Given this list of marker genes CDC25C, PCBP4, CCNA2, SFN, E2F1, CCNE1, CNOT10, RGCC, CCNB1, CNOT3, BTG2, RBL1, E2F8, CNOT4, TNKS1BP1 (NCBI Gene Id 85456), CDKN1A, CNOT8, CARM1, ZNF385A, PCNA, PLK2, E2F4, PRMT1, BAX, CNOT7, E2F7, CNOT2, CNOT6, CNOT1, NPM1, CPAP, EP300, ARID3A, CDKN1B, RBL2, CNOT11, CCNE2, PLK3 (NCBI Gene Id 1263), TP53, CDK2, PLAGL1, CDK1, CCNA1, TFDP2, GADD45A, TFDP1, CNOT9, CNOT6L (NCBI Gene Id 91275), AURKA, here is a description of the gene set: species: Homo sapiens Under a variety of stress conditions, TP53 (p53), stabilized by stress-induced phosphorylation at least on S15 and S20 serine residues, can induce the transcription of genes involved in cell cycle arrest. Cell cycle arrest provides cells an opportunity to repair the damage before division, thus preventing the transmission of genetic errors to daughter cells. In addition, it allows cells to attempt a recovery from the damage and survive, preventing premature cell death.<p>TP53 controls transcription of genes involved in both G1 and G2 cell cycle arrest. The most prominent TP53 target involved in G1 arrest is the inhibitor of cyclin-dependent kinases CDKN1A (p21). CDKN1A is one of the earliest genes induced by TP53. CDKN1A binds and inactivates CDK2 in complex with cyclin A (CCNA) or E (CCNE), thus preventing G1/S transition. Nevertheless, under prolonged stress, the cell destiny may be diverted towards an apoptotic outcome. For instance, in case of an irreversible damage, TP53 can induce transcription of an RNA binding protein PCBP4, which can bind and destabilize CDKN1A mRNA, thus alleviating G1 arrest and directing the affected cell towards G2 arrest and, possibly, apoptosis. Expression of E2F7 is directly induced by TP53. E2F7 contributes to G1 cell cycle arrest by repressing transcription of E2F1, a transcription factor that promotes expression of many genes needed for G1/S transition. ARID3A is a direct transcriptional target of TP53 that may promote G1 arrest by cooperating with TP53 in induction of CDKN1A transcription. However, ARID3A may also promote G1/S transition by stimulating transcriptional activity of E2F1.<p>TP53 contributes to the establishment of G2 arrest by inducing transcription of GADD45A and SFN, and by inhibiting transcription of CDC25C. TP53 induces GADD45A transcription in cooperation with chromatin modifying enzymes EP300, PRMT1 and CARM1. GADD45A binds Aurora kinase A (AURKA), inhibiting its catalytic activity and preventing AURKA-mediated G2/M transition. GADD45A also forms a complex with PCNA. PCNA is involved in both normal and repair DNA synthesis. The effect of GADD45 interaction with PCNA, if any, on S phase progression, G2 arrest and DNA repair is not known. SFN (14-3-3-sigma) is induced by TP53 and contributes to G2 arrest by binding to the complex of CDK1 and CCNB1 (cyclin B1) and preventing its translocation to the nucleus. Phosphorylation of a number of nuclear proteins by the complex of CDK1 and CCNB1 is needed for G2/M transition. While promoting G2 arrest, SFN can simultaneously inhibit apoptosis by binding to BAX and preventing its translocation to mitochondria, a step involved in cytochrome C release. TP53 binds the promoter of the CDC25C gene in cooperation with the transcriptional repressor E2F4 and represses CDC25C transcription, thus maintaining G2 arrest (St Clair et al. 2004, Benson et al. 2014).<p>Several direct transcriptional targets of TP53 are involved in cell cycle arrest but their mechanism of action is still unknown. BTG2 is induced by TP53, leading to cessation of cellular proliferation. BTG2 binds to the CCR4-NOT complex and promotes mRNA deadenylation activity of this complex. Interaction between BTG2 and CCR4-NOT is needed for the antiproliferative activity of BTG2, but the underlying mechanism has not been elucidated. Two polo-like kinases, PLK2 and PLK3, are direct transcriptional targets of TP53. TP53-mediated induction of PLK2 may be important for prevention of mitotic catastrophe after spindle damage. PLK2 is involved in the regulation of centrosome duplication through phosphorylation of centrosome-related proteins CENPJ and NPM1. PLK2 is frequently transcriptionally silenced through promoter methylation in B-cell malignancies. Induction of PLK3 transcription by TP53 may be important for coordination of M phase events through PLK3-mediated nuclear accumulation of CDC25C. RGCC is induced by TP53 and implicated in cell cycle regulation, possibly through its association with PLK1. PLAGL1 (ZAC1) is a zinc finger protein directly transcriptionally induced by TP53. PLAGL1 expression is frequently lost in cancer and PLAGL1 has been implicated in both cell cycle arrest and apoptosis, but its mechanism of action remains unknown.<p>The zinc finger transcription factor ZNF385A (HZF) is a direct transcriptional target of TP53 that can form a complex with TP53 and facilitate TP53-mediated induction of CDKN1A and SFN (14-3-3 sigma) transcription.<p>For a review of the role of TP53 in cell cycle arrest and cell cycle transcriptional targets of TP53, please refer to Riley et al. 2008, Murray-Zmijewski et al. 2008, Bieging et al. 2014, Kruiswijk et al. 2015. part of: Transcriptional Regulation by TP53 Reactome Pathway: TP53 Regulates Transcription of Cell Cycle Genes